Given this list of marker genes RAB11FIP2, PKP1, EPHA2 (EPH receptor A2), PDZK1, KIF5B, IFNG, MYO1C, HPCA, ARF6, RAC1, FYN, COMMD1, EFCAB7, CACNG2, EPHA3, PIK3R1, VIL1, AKT1, TREM2, MIR223, DLG1, RER1, CRKL, STAC2, TNFAIP6, LRP4, STX4, SLC51B, RHOG, CNPY4, CDK5R1, ACSL3, RACK1, C2CD5, ATP2C1, STAC, EZR, ITGB1, RAMP3, ANXA13, LRP1 (NCBI Gene Id 4035), ERBB2, PAK1, STOM, ZDHHC2, CEMIP, PRNP, ITGA3, DOK7, GPER1 (NCBI Gene Id 2852), AP2B1, ARHGEF16, PDPK1, TCAF2, FNTA, AKT2, RANGRF, PRKN, AKAP5, STX3, CDK5, AGR2, TNF, ITGB2, STAC3, NLGN2, PRKCH, WNK3, TCAF1, WNT3A, MIEF2, ZDHHC5, NRXN1, PTPN9, EPHB2, MIEF1, PPP1R9B, ZDHHC8, MTCL1, LGALS3, CHP1, DPP10, PLS1, PRKCE, ITGB1BP1, SQSTM1, CD81, SORBS1, CLN3, ITGAM, SSH1, CIB1, HRAS, NKD2, CLIP3, PGRMC1, MESD, NECAB2, PRKCI, RAB11A, SPTBN1, FARP1, CNST, EGFR, SLC5A3, ATP2B4, KCNB1, DSG3, CRK, ANK3, PIK3CA, here is a description of the gene set: Human Gene Set: GOBP_POSITIVE_REGULATION_OF_PROTEIN_LOCALIZATION_TO_MEMBRANE species: Homo sapiens Any process that activates or increases the frequency, rate or extent of protein localization to membrane.